The following is a description of a gene set: part of: Toll-like Receptor Cascades Reactome Pathway: Toll Like Receptor 7/8 (TLR7/8) Cascade species: Homo sapiens RNA can serve as a danger signal, both in its double-stranded form as well as single-stranded RNA (ssRNA). Toll like receptor 7 (TLR7) and TLR8 are endosomal receptors that sense ssRNA oligonucleotides containing guanosine (G)- and uridine (U)-rich sequences from RNA viruses (Jurk M et al. 2002; Heil F et al. 2004; Diebold SS et al. 2004; Li Y et al. 2013; reviewed in Lester SN & Li K 2014). TLR7 is primarily expressed in plasmacytoid dendritic cells (pDCs) and, to some extent, in B cells, monocytes and macrophages, whereas TLR8 is mostly expressed in monocytes, macrophages and myeloid DCs. Upon engagement of ssRNAs in endosomes, TLR7/8 initiate the myeloid differentiation factor 88 (MyD88)-dependent pathway, culminating in synthesis of type I and type III IFNs and proinflammatory mediators via activation of IFN regulatory factors (IRF7, IRF5) and NF-kappaB, respectively, depending on the cell type (Takaoka A et al., 2005; Heinz LX et al., 2020; reviewed in Lester SN & Li K 2014). TLR7 and TLR8 are able to detect GU-rich ssRNA sequences from the viral genomes of influenza, human immunodeficiency virus-1 (HIV-1), vesicular stomatitis virus (VSV), coxsackie B virus, coronavirus and flaviviruses (hepatitis C virus, HCV and West Nile virus, WNV; reviewed in Lester SN & Li K 2014). Specifically, GU-rich ssRNA oligonucleotides derived from HIV-1, for example, stimulate dendritic cells (DC) and macrophages to secrete interferon-alpha and proinflammatory, as well as regulatory, cytokines (Heil F et al. 2004). This has been found to be mediated by TLR7, as well as TLR8. Similarly, severe acute respiratory syndrome-associated coronavirus type 1 (SARS-CoV-1) GU-rich ssRNAs had powerful immunostimulatory activities in mononuclear phagocytes to induce considerable level of pro-inflammatory cytokine TNF-a, IL-6 and IL-12 release via the TLR7 and TLR8 (Li Y et al. 2013). Further, mice deficient in either Tlr7 or the TLR adaptor protein Myd88 demonstrated reduced responses to in vivo infection with VSV (Lund JM et al. 2004), mouse-adapted SARS-CoV-1. Upon Middle East respiratory syndrome-related coronavirus (MERS-CoV) infection, lack of MyD88 signaling resulted in delayed viral clearance and increased lung pathology in mice. Consistently, another study showed that Tlr7-/- mice have reduced IFN expression compared with wild-type mice. In addition, loss of function TLR7 variants identified in the patients with SARS-CoV-2 (COVID-19) resulted in defective upregulation of type I IFN–related genes in the TLR7 pathway (Figure 3) in response to the TLR7 agonist imiquimod as compared with controls (Van der Made CI et al. 2020). Separate studies showed that synthetic imidazoquinoline compounds (e.g. imiquimod and R-848, low-molecular-weight immune response modifiers that can induce the synthesis of interferon-alpha) also exert their effects in a MyD88-dependent fashion through TLR7 or TLR8 (Hemmi H et al. 2002; Jurk M et al. 2002; Diebold SS et al. 2004). Some viruses utilize multiple strategies to evade antiviral innate immune signaling, as is seen with influenza or SARS coronaviruses. TLR7-mediated innate immunity, for example, was associated with the negative regulation through removing Lys63-linked polyubiquitin chains of TRAF3/TRAF6 by papin-like protease (PLpro) catalytic domain of nsp3 from SARS-CoV-1 (Li SW et al. 2016). Thus, TLR7 and TLR8 play a critical role in sensing of viral ssRNA in the endosome., and this is the list of marker genes: DUSP3, NFKBIA, MAPK9, PELI2, MAP2K4, IRAK2, UBE2N, NOD1, MAP2K7, ELK1, RIPK2, LRRC14, MAPK11, NOD2, TASL, N, UBC, MYD88, TAB1, IRF5, MAP3K8, TNIP2, SKP1 (S-phase kinase associated protein 1), PPP2R5D, MAP3K1, N4BP1, MAP2K3, FBXW11, UBB, TLR7, IKBKG, TICAM1, PPP2CA, JUN, PELI1, IKBKB, MAPK3, CHUK, ATF1, NFKB2 (NCBI Gene Id 4791), UBA52, TAB3, ECSIT, ALPK1, PPP2R1A, MAPKAPK3, MAPK1, BTRC, FOS, RPS6KA5, MAPK8, ATF2, MAP3K7, DUSP7, PPP2R1B, LY96, TP53, IRAK1, TLR9, NKIRAS1, DUSP6, TRAF6, MAPK14, CREB1, TLR4, RPS6KA1, UBE2V1, PPP2CB, RPS27A, PELI3 (NCBI Gene Id 246330), NKIRAS2, CUL1, MAPKAPK2, NFKBIB, TRAF2, S100B, USP18, S100A12, TAB2, HMGB1, MAPK7, TLR8, MEF2A, VRK3, MAPK10, AGER, NFKB1, NLRX1, MAP2K1, TIFA, RELA, NLRC5, RPS6KA2, CD14, SLC15A4, MAP2K6, APP (amyloid beta precursor protein), IRF7, IKBIP, TICAM2, IRAK4, USP14, DUSP4, RPS6KA3, SAA1 (serum amyloid A1), CASP8, MEF2C